The following is a description of a gene set: Mouse Gene Set: GOBP_REGULATION_OF_NK_T_CELL_DIFFERENTIATION Any process that modulates the frequency, rate or extent of natural killer T cell differentiation. studied in species Mus musculus, and this is the list of marker genes: Ap3b1, Zfp683, Prdm1, Ap3d1, Tgfbr2, Cd1d1